The following is a description of a gene set: Human Gene Set: GOBP_POSITIVE_REGULATION_OF_COLLATERAL_SPROUTING studied in species Homo sapiens Any process that activates or increases the frequency, rate or extent of collateral sprouting., and this is the list of marker genes: SEMA4D, BDNF, CRABP2, WNT3A, IST1, BCL11A, LPAR3, RND2, WNT3, NGF, EFNA5